The following is a description of a gene set: Reactome Pathway: activated TAK1 mediates p38 MAPK activation This event has been computationally inferred from an event that has been demonstrated in another species.<p>The inference is based on the homology mapping from PANTHER. Briefly, reactions for which all involved PhysicalEntities (in input, output and catalyst) have a mapped orthologue/paralogue (for complexes at least 75% of components must have a mapping) are inferred to the other species. part of: MAP kinase activation electronically inferred by orthology from the curated human pathway studied in species Mus musculus, and this is the list of marker genes: Map2k6, Ube2n, Ubb, Ube2v1, Tab2, Mapk14, Mapk11, Map2k3, Tab3 (NCBI Gene Id 66724), Rps27a, Tab1, Irak1